The following is a description of a gene set: studied in species Homo sapiens We identified Pparg as a major orchestrator of the phenotype of adipose-tissue resident regulatory T cells (VAT Tregs). To establish the role of Pparg in shaping the VAT Tregs gene profile and cell dynamics, Tregs from lymph nodes and visceral adipose tissue of mice sufficient and deficient of Pparg expression in Tregs were double sorted for microarray analysis. from publication Cipolletta D, Feuerer M, Li A, Kamei N, Lee J, Shoelson SE, Benoist C, Mathis D (PMID 22722857) Human Gene Set: GSE37532_WT_VS_PPARG_KO_VISCERAL_ADIPOSE_TISSUE_TREG_UP Genes up-regulated in T reg from visceral adipose tissue of aged mice: wildtype versus PPARG knockout., and this is the list of marker genes: CBX5, TMSB15A, MLLT10, HNRNPA2B1, ZCCHC10, CDC27, RALBP1, CLIC4, LSM3, KPNA2, HAUS8, YWHAZ, KIF18A, PNRC2 (proline rich nuclear receptor coactivator 2), CD27, HNRNPM, E2F2, NUSAP1, ARHGAP33, ECT2, PAPSS1, NSD2, WDR19, HMGN2, SARNP, CDC25B, ENSG00000284634, PHF3, H1-10, SRP9, SPIN4, RANGAP1, SAE1, COP1, ACRBP, PSIP1, NDC80, TAPT1 (NCBI Gene Id 202018), CDC7, GTSE1, TRIOBP, FBXO5, ANAPC11, REXO5, MFHAS1, SPA17, CDC25C, CCNF, FAM111B, ANKRD36, CTCF, HMGB3P1, IQGAP1, CEP20, HMGB2, JPT1, SGO2, CETN3, HP1BP3, PAPOLG, PRC1, TUG1, IFT122, CARHSP1, TYMS, ESPL1 (extra spindle pole bodies like 1, separase), TUBB4B, RFC4, ITPR1, SPAG16, ILK, CENPJ, CCDC34, PHKB, ZDHHC14 (NCBI Gene Id 79683), RAP1B, TRMT5, MXD3, CPPED1, CENPI, RNF26, IQGAP3, GPSM2, NAP1L4, HMGB3, CKAP2L, DEPDC1B, TRIP13, TPX2, PCLAF, ACKR4, SLBP, PRDM10, H2AZ2, SAP130, MRPL51, GCSAM, TUBA1C, PTTG3P, CDKN2C, LRRFIP2, SPAG5, TERF2, CALM3, KIF4A, BACH2, EME1, SANBR, DPY30, H2AX, DIAPH3, MPC2, PTP4A2, TACC3, POLH, HCFC2 (NCBI Gene Id 29915), MTM1, CYTH2, DCP2, PKMYT1, HSPA2, PPP6C, C6orf226, NRM, RAD54L, WDR47, ARHGAP11A (NCBI Gene Id 9824), CTNNAL1, RPS27L, TPD52, GPR137C, TAPT1-AS1, STMN1, DEPDC1, PLK4, DESI2, POC1A, HDGF, BIRC5, CDCA5, CCNE1, ANKRD36BP2 (ankyrin repeat domain 36B pseudogene 2), TRIM59, NT5C2, TROAP, DTYMK, FANCI, KIF14, DLGAP5, OIP5, EZR, CCDC150, CDKN3, ZNF367, TMPO, KIF2C, RRM1, CDK19, CGGBP1, HPS4, CDCA8, PEX5, TMEM129, SLC25A20, TDRD7, DUT, JMJD1C, RPRD2, SAPCD2, ARHGAP19, DCTN3, DONSON, RRM2B (ribonucleotide reductase regulatory TP53 inducible subunit M2B), SEPHS1, CFAP251, TRIM24 (NCBI Gene Id 8805), GINS2, CPSF6, UBL7-DT, SYF2, DEK, UBE2T, TCL6, MME, CKS1B, CEP76, SKA1, DCTN2, C18orf54, H2AJ, RTTN, TCF3, SLC30A4, STIL, MELK, ATP6V1G3, ATP23, DGKZ, TCEA1